The following is a description of a gene set: studied in species Homo sapiens from publication Lucas B, Grigo K, Erdmann S, Lausen J, Klein-Hitpass L, Ryffel GU (PMID 16007190) Human Gene Set: LUCAS_HNF4A_TARGETS_UP Genes up-regulated in Tet-On HEK293 cells (embryonic kidney) by expression of HNF4A. Hepatocyte nuclear factor 4alpha (HNF4alpha) is a tissue-specific transcription factor known to regulate a large number of genes in hepatocytes and pancreatic beta cells. Although HNF4alpha is highly expressed in some sections of the kidney, little is known about its role in this organ and about HNF4alpha-regulated genes in the kidney cells. The abundance and activity of HNF4alpha are frequently reduced in renal cell carcinoma (RCC) indicating some tumor suppressing function of HNF4alpha in renal cells. To determine the potential role of HNF4alpha in RCC, we used Flp recombinase-mediated gene integration to generate human embryonic kidney cells (HEK293) that conditionally express wild-type or mutated HNF4alpha. Expression of wild-type HNF4alpha but not of the mutants led to reduction of proliferation and alterations of cell morphology. These effects were reversible and induced at physiological concentrations of HNF4alpha. Using gene expression profiling by microarrays, we determined genes regulated by HNF4alpha. Interestingly, many of the genes regulated by HNF4alpha have been shown to be deregulated in RCC microarray studies. These genes (ACY1, WT1, SELENBP1, COBL, EFHD1, AGXT2L1, ALDH5A1, THEM2, ABCB1, FLJ14146, CSPG2, TRIM9 and HEY1) are good candidates for genes whose activity is changed upon the decrease of HNF4alpha in RCC., and this is the list of marker genes: DDAH2, DSC2, SELENOP, KIFAP3, ACADVL, SLC25A20, ALDH5A1, TRAF4 (NCBI Gene Id 9618), KIF13B, EFHD1, HNF4A, SLC35D1 (NCBI Gene Id 23169), ACOT13, SELENBP1, PRPH, ATP7B, MPP1, CDIP1, WT1, TECR, ETNPPL (ethanolamine-phosphate phospho-lyase), COL21A1, ERBB3, PKP2, SLCO4C1, COBL (NCBI Gene Id 23242), SDC4, ETFDH, EBP, CIDEB, IL18R1, CFLAR, C1orf115, AKAP1, ATXN7L1, NID1, MGST2, PRKCSH, BIRC2, OSBPL3, ACOX1, MAN1A1, CAMKK2, IL13RA1, ACY1, ABCB4, PKIG, MTM1, DNAJC22, TACC2, CALML4 (calmodulin like 4), SMAGP, VIL1, LASP1, ABCB1, DHRS1, DERA, RBKS